Given this list of marker genes HLA-G, PSG9, AIRE, HAVCR2, FOXP3, here is a description of the gene set: species: Homo sapiens Human Gene Set: GOBP_TOLERANCE_INDUCTION_DEPENDENT_UPON_IMMUNE_RESPONSE Tolerance induction dependent upon an immune response, typically a response by a mature T or B cell in the periphery resulting tolerance towards an antigen via induction of anergy, cellular deletion, or regulatory T cell activation.